Given this list of marker genes Plau, Plg, Plat, Serpine1, S100a10, Hrg, Serpine2, Plaur, Serpinb8, Serpinb2, Serpinb6a, Serpinf2, Anxa2, here is a description of the gene set: studied in species Mus musculus Dissolution of Fibrin Clot Mouse Gene Set: REACTOME_DISSOLUTION_OF_FIBRIN_CLOT